Given this list of marker genes TGFB3 (transforming growth factor beta 3), MSX1, TMEM100, RBPJ, SMAD4, TGFB1, TGFB2, MSX2, ENG, SNAI2, HEYL, HEY2, TGFBR1, FGF8, BMP4, TGFBR2, NOTCH1, SNAI1, here is a description of the gene set: studied in species Homo sapiens Human Gene Set: GOBP_EPITHELIAL_TO_MESENCHYMAL_TRANSITION_INVOLVED_IN_ENDOCARDIAL_CUSHION_FORMATION A transition where a cardiac epithelial cell loses apical/basolateral polarity, severs intercellular adhesive junctions, degrades basement membrane components and becomes a migratory mesenchymal cell that will contribute to the formation of the endocardial cushion.